The following is a description of a gene set: The chemical reactions and pathways resulting in the breakdown of proteoglycans, any glycoprotein in which the carbohydrate units are glycosaminoglycans. species: Mus musculus Mouse Gene Set: GOBP_PROTEOGLYCAN_CATABOLIC_PROCESS, and this is the list of marker genes: Ctsl, Naglu, Adamts12, Sgsh, Hexa, Hexb, Hyal4, Idua, Gusb, Gns, Glb1, Hyal1, Btk, Gpc1, Hpse, Ids (NCBI Gene Id 15931), Hgsnat, Arsb, Galns